Given this list of marker genes PRRX1, EHMT2, ASCL1 (NCBI Gene Id 429), PTF1A (pancreas associated transcription factor 1a), NFIB, GBX1, RBPJ (recombination signal binding protein for immunoglobulin kappa J region), TLX3, OLIG3, DLX1, FEV, DMRT3, SUFU, LBX1, SOX9, SOX1, POU4F1, CTNNB1, JAG2, HOXD10, NOTCH3, ARX, ID2, NOTCH1, CDC42, PAX7, POU3F2, LHX3, OLIG2, ZDHHC16, ATOH7, GSX1, BCL11B, NKX2-1, GSX2, GLI3, WNT1, HOXC10, MNX1, OLIG1, TGFBR1 (transforming growth factor beta receptor 1), IHH, ISL1, EYA1, EPOP, ISL2, GATA2, DBX1, ZNF521, TGFB2, NFIA, NTRK3, NKX6-2, MIR125A, SHH, SIX1, PAX6, GLI2, TBR1, NKX2-2, LMO4, TFAP2C, DLL1, FKBP8, PROX1, SMAD4, DLX2, MYT1L, ESRP1, ATOH1, DLL4, FOXA1, FEZF2, BMP4, DMRTA2, FOXG1, FOXN4, here is a description of the gene set: The process in which the developmental fate of a cell becomes restricted such that it will develop into a neuron. studied in species Homo sapiens Human Gene Set: GOBP_NEURON_FATE_COMMITMENT